Given this list of marker genes IL2RA, PRG4, IL2RB (NCBI Gene Id 3602), CD247, ANKRD55, STAT4, PTPN2, PTPN22, here is a description of the gene set: Synovial lining hyperplasia studied in species Homo sapiens Synovial hyperplasia involves proliferation of mesenchymal stromal/stem cells and leads to synovial thickening, which can be observed radiographically. Human Gene Set: HP_SYNOVIAL_LINING_HYPERPLASIA